The following is a description of a gene set: Human Gene Set: GOCC_ENDONUCLEASE_COMPLEX species: Homo sapiens A protein complex which is capable of endonuclease activity., and this is the list of marker genes: TSNAX (NCBI Gene Id 7257), POP5, AGO4, AGO1, LAS1L, ERN1, DROSHA, EME2, WDR18, EME1, TRMT10C, DGCR8, POP7, AGO3, RPP25, DHX9, RPP30 (ribonuclease P/MRP subunit p30), TSN, RPP14, RPP40, POP1, PRORP, RAG1, RPPH1, AGO2, HSD17B10, POP4, RPP21, RPP38, TSEN2, PRKRA, TSEN34, MUS81, TSEN54, TARBP2, SLX4, DICER1, CLP1, RPP25L